The following is a description of a gene set: Mouse Gene Set: CUI_ILC_IL1B_RESPONSE_UP Genes positively differentially expressed in cell type: ILC (innate lymphoid cell) upon treatment with cytokine: IL-1β in mouse lymph nodes in vivo. studied in species Mus musculus Cytokines mediate cell-cell communication in the immune system and represent important therapeutic targets. A myriad of studies have highlighted their central role in immune function, yet we lack a global view of the cellular responses of each immune cell type to each cytokine. To address this gap, the authors created the Immune Dictionary, a compendium of single-cell transcriptomic profiles of more than 17 immune cell types in response to each of 86 cytokines (>1,400 cytokine-cell type combinations) in mouse lymph nodes in vivo. A cytokine-centric view of the dictionary revealed that most cytokines induce highly cell-type-specific responses. For example, the inflammatory cytokine interleukin-1β induces distinct gene programmes in almost every cell type. A cell-type-centric view of the dictionary identified more than 66 cytokine-driven cellular polarization states across immune cell types, including previously uncharacterized states such as an interleukin-18-induced polyfunctional natural killer cell state. from publication Cui A, Huang T, Li S, Ma A, Pérez JL, Sander C, Keskin DB, Wu CJ, Fraenkel E, Hacohen N (PMID 38057668), and this is the list of marker genes: Slc15a3, Cx3cl1, Rpn1, Ostf1, Batf, Bcl2a1d, Manf (NCBI Gene Id 74840), Prdx6, Cd83, Bcl2a1b, Rel, Tnfrsf9, Atf5, Il4i1, Gzmc, Basp1, Mir155hg, Gtpbp4, Csf2